The following is a description of a gene set: Blood vessel formation when new vessels emerge from the proliferation of pre-existing blood vessels and contribute to the series of events that restore integrity to a damaged tissue, following an injury. Human Gene Set: GOBP_ANGIOGENESIS_INVOLVED_IN_WOUND_HEALING studied in species Homo sapiens, and this is the list of marker genes: GPX1, TAFA5, CD34, ADIPOR2, MCAM, NPR2, ITGB3, CX3CL1, HPSE, SMOC2, MIR34A, MIR200B, ALOX5 (NCBI Gene Id 240), TNF, GPR4, KDR, MIR451A, PIK3CB, FOXC2, VEGFA, GATA2 (GATA binding protein 2), MIR1298, TNFAIP3, B4GALT1, SERPINE1, DAG1, HTN1, SRF, NDNF, PRCP, VEGFB, SLC12A2, XBP1